Given this list of marker genes ELOC (elongin C), EIF4E, CNOT2, DICER1, PAIP1, CNOT8, NOBOX, TNKS1BP1, CNOT9, AGO2, RPS2 (ribosomal protein S2), EIF4G1, EIF4B, CNOT6L, ZFP36L2, CNOT7, EIF4A2, CNOT11, CNOT10, PAIP2, POLR2D, CNOT3, FGF8, BTG4, CNOT4, EIF4A3, PABPN1L, EIF4A1, PABPC1, CNOT1, PADI6, ZP2 (zona pellucida glycoprotein 2), CNOT6 (CCR4-NOT transcription complex subunit 6), here is a description of the gene set: M-decay: degradation of maternal mRNAs by maternally stored factors studied in species Homo sapiens Human Gene Set: REACTOME_M_DECAY_DEGRADATION_OF_MATERNAL_MRNAS_BY_MATERNALLY_STORED_FACTORS